The following is a description of a gene set: from publication Lynch SJ, Zavadil J, Pellicer A (PMID 23755101) It has been recently shown that N-ras plays a preferential role in immune cell development and function; specifically: N-ras, but not H-ras or K-ras, could be activated at and signal from the Golgi membrane of immune cells following a low level TCR stimulus. The goal of our studies was to test the hypothesis that N-ras and H-ras played distinct roles in immune cells at the level of the transcriptome. First, we showed via mRNA expression profiling that there were over four hundred genes that were uniquely differentially regulated either by N-ras or H-ras, which provided strong evidence in favor of the hypothesis that N-ras and H-ras have distinct functions in immune cells. We next characterized the genes that were differentially regulated by N-ras in T cells following a low-level TCR stimulus. Of the large pool of candidate genes that were differentially regulated by N-ras downstream of TCR ligation, four genes were verified in qRT-PCR-based validation experiments as being differentially regulated by N-ras (Dntt, Slc9a6, Chst1, and Lars2). Finally, although there was little overlap between individual genes that were regulated by N-ras in unstimulated thymocytes and stimulated CD4+ T-cells, there was a nearly complete correspondence between the signaling pathways that were regulated by N-ras in these two immune cell types. Since we were interested primarily in genes that were differentially regulated by N-ras following a low-level TCR stimulus, our microarray data comparison was between data from TCR-stimulated, WT CD4+ T-cells and from TCR-stimulated, N-ras KO CD4+ T-cells. Genes that were differentially regulated in the comparison between stimulated N-ras KO CD4+ T-cells and unstimulated N-ras KO CD4+ T-cells, as well as those genes that were differentially regulated in the comparison between stimulated WT CD4+ T-cells and unstimulated WT CD4+ T-cells were excluded from this analysis. To determine if N-ras and H-ras regulate different sets of genes in thymocytes, a comparison was made between the set of genes that were differentially regulated by N-ras in the vs. comparison and the set of genes that were differentially regulated by H-ras in the vs. comparison. Genes down-regulated in CD4 T cells with NRAS knockout: unstimulated versus activated. Human Gene Set: GSE45739_UNSTIM_VS_ACD3_ACD28_STIM_NRAS_KO_CD4_TCELL_DN studied in species Homo sapiens, and this is the list of marker genes: RNF40, GYG1, SPON2, C1orf21, CHSY1, PRF1, DYSF, P2RY14, DENND2B, ARPC5L, KIR2DL5A, BPGM, PCDH9, SLC25A4, CD248, PDE4A, TCF4, SPHK1, MTCL1, SLC17A9, PDGFD, KLRD1, ISG20L2, GZMK, GFI1, ROR1, PDGFA, CCNA1, SLC2A1, PALLD, PLAAT3, SLC1A7, KLRF1, ADRB2, BZW1, MATK, GAS7, PLCG2, SSX2IP, AOAH (NCBI Gene Id 313), CLCN6, MXRA7, PDLIM1 (NCBI Gene Id 9124), GALNT3, CD63, CD72, CASZ1, LITAF, MED14OS, NME8, DKK3, ABCB1, SPRING1, PHACTR1, CST7, GOLM1, F2R, SYNGR3, NT5E, PTPN12, GSE1, FAM30A, GTF3C1, ITGAM, PRSS23 (NCBI Gene Id 11098), CMA1, HLA-C, MAP3K8, GGA2, SPIB, PKIG, PTPN22, PAX5, AUTS2, TGFBR3, CACNA2D2, PLEK (pleckstrin), HDAC9, SCCPDH, CDY1, CBLB, B3GAT1, KLRC3, ACOX2, KIR3DS1, CTSW, PTPRK, KIR2DL1 (killer cell immunoglobulin like receptor, two Ig domains and long cytoplasmic tail 1), RIT1, GATAD2A, CD19, RAB5IF, TTC38, NUDT11, ITCH, STAG3, GZMA, KIR2DL2, XCL1, TNFRSF9, KIR2DL4, FAT4, S1PR5, MT1F, GZMH, CCL4, NCR3, GPR65, GNLY, CD8A, DLG3, TSPOAP1, IL12A, CCL5, CHST12, CD160, TMEM97, BFSP1, GALNT1, HIP1, HLA-DMB, ANTKMT, DLG5, NUAK1, MVB12B, PLXND1, EFHD2, LAG3, NIP7, CRTAM, HLA-DMA, VAV3, GTDC1, USP11, PTPRB, HOMER1 (homer scaffold protein 1), ID2, LYVE1, MCTP2, FAM3C (FAM3 metabolism regulating signaling molecule C), BCL7A, CD244, ARHGAP26, ADGRG1, KLRC4, APMAP, PLEKHF1, SEMA4A, SIPA1L3, UBB, FASLG, RABIF, RHOQ, ATP8A1, KIR2DS2, RUNX3, CD79A, CDK14, GZMB, CD8B, TLE1, IL2RB, ZFTA (zinc finger translocation associated), HOXC4, HLA-A, CLIC3, KIR2DS5, DBN1, FYN, RHBDF2, FEZ1, TLR3, YBX3, TSPAN3, ITPK1, SLAMF7, CRIM1, CAMK2N1, KIR2DL3, CHST10, SH2D2A, RRAS2, KIN, RGS9, SERTAD3, BNC2 (NCBI Gene Id 54796), SYBU, ZEB2, COLGALT2, GFOD1, NKG7, DNMBP, AGAP1, GALNT11, ENC1, SPARCL1, TBX21, MYO6, KLRK1